Given this list of marker genes IFNA5, PTPN11, SOCS1, IFNB1, IFNA2, IFNA8, IFNAR1, JAK1, IFNA16 (interferon alpha 16), TYK2, STAT1, IFNA10, STAT2, PTPN6, IFNA21, IFNAR2, SOCS3, PTPN1, IFNA13, IFNA17, IFNA4, IFNA7, IFNA6, IFNA14, IFNA1, USP18, here is a description of the gene set: studied in species Homo sapiens Human Gene Set: REACTOME_REGULATION_OF_IFNA_IFNB_SIGNALING Regulation of IFNA/IFNB signaling